The following is a description of a gene set: Mouse Gene Set: GOBP_NEGATIVE_REGULATION_OF_TYPE_B_PANCREATIC_CELL_APOPTOTIC_PROCESS species: Mus musculus Any process that stops, prevents or reduces the frequency, rate or extent of type B pancreatic cell apoptotic process., and this is the list of marker genes: Cast, Tcf7l2, Atg7, Pdx1, Ngf, Wfs1, Srsf6, Neurod1